The following is a description of a gene set: An abnormality of the regulation of body fluids. Human Gene Set: HP_ABNORMALITY_OF_FLUID_REGULATION Abnormality of fluid regulation studied in species Homo sapiens, and this is the list of marker genes: LCT, ATN1, SCNN1G, DOHH, MMACHC, TGFB1, SLC25A4, MVK, ITK, PTEN (NCBI Gene Id 8037), NUP85, SEC63, ACVR1, PSAT1, ACBD6, ACP5, FOXG1, BCL2, TXNRD2, ANKH, FECH, VSX1, ALG9, ADAMTS2, JAG1, COX16, GPC6, HNRNPK (heterogeneous nuclear ribonucleoprotein K), PEX5, PSMG2, DPAGT1, MYH7, KRT13, LAMA3, RBM20, INPPL1, TNFRSF1B, TLR4, COQ8B, SCN9A, PCCB, ALPK3, TNNC1, NIPAL4, MCM10, CLMP, LAMB3, ACTN4, MYPN, TGM1 (NCBI Gene Id 7051), USP8, ZNHIT3, BUD23, GATM, LAMB2, SLC34A2, HGD, FARSB, RRAS (NCBI Gene Id 6237), CASP10, GPR101, ERAP1, FBXO11, DSP, UROS, PSEN2, MEN1, SLC4A11, IL2RB, HELLPAR, ACADM, TAF6, MYH6, ATP6V0A4, TRIP11, CPN1, EFEMP1, IL6, GATB, MST1, RBM8A, NEXN, RRM2B, KIF20A, AQP2, GET3, GNPTAB, SCN11A (NCBI Gene Id 337933), PERCC1, PIEZO1, CAV1 (NCBI Gene Id 857), TBK1, SDHA, LAMC2, KLHL40, THSD1, EPCAM, EHHADH, FRMD4A, WDR35, IVD, KLHL41, F8, PLXND1, CCBE1, CYBB, MYL11, GTF2I, TCF4, NUP37, TMEM260, NEU1, NUP160, KCNN4, DEF6, COL8A2, WT1, IL23R (interleukin 23 receptor), FCGR2A, IL12A-AS1, DCHS1, CYC1, RIN2, SNORD116-1, ACAD9, MAPRE2, BMPR1A, ANTXR2, DNMT1, VPS51, EPB41, MYD88, CTNNB1, FASLG, ANGPT1, SLC12A1, RPL3L, IYD, CD79A, SLC5A1, GLB1, TSHR, SGPL1, IL10, ACSF3 (acyl-CoA synthetase family member 3), KIAA0586, ZNF408, MECOM, NDP (norrin cystine knot growth factor NDP), SPG11, HLA-B, GLA, BMP6, RPS10, SOS1, PRKCSH, GAPVD1, WNT7A, ADARB1, AVPR2 (NCBI Gene Id 554), ERBB3 (erb-b2 receptor tyrosine kinase 3), POMP, LAMA2, TAF1A, PTPN22, PSMB4, CCND1 (cyclin D1), TXNDC15, HPGD, CRB2, SPTB, LRP5, RYR1, ERG, GATA6, PCCA (NCBI Gene Id 5095), HESX1, HSD3B2, FIBP, CDKN1B, CBL, RAP1B, PTPN2, NAA10, MMUT, NUP205, CD247, PIK3CA, FHL2, KLF1, SLC1A3, CD244, SPINK1, AP1S3, IRAK1, PRKAR1A, RNF13, RAF1, CHD7, CALR, ALG1, EIF2AK3, LDB3, DYNC2I1, BLNK, RBMX, NDUFAF6, ADA, DHX30, PRKAG2, NPAP1 (nuclear pore associated protein 1), MPV17, AGXT, ARHGAP24, PLN, TICAM1, MT-CYB, TALDO1, SEMA4D, RRAGC, ASAH1, IGHM, TNNT2, TAFAZZIN, SLC29A3, SLC5A2, TMEM270, NSF, ADAMTS3, FZD4, KIF7, IFT140, NR3C1, FSHR, SLC4A1, B4GALT1, NRAS, PLVAP, TRPC6, MAP2K2, PKLR, NARS2, SLC25A13, ATP7B, SLC26A4, TBC1D8B, IL7R, FAS, F12, DOK7, HBA1, SPINK5, NKX2-6, NDUFS4, ASS1, EMP2, TNNI3, GCK, SLC5A5, SLC26A2, ALG12, CPT2, VCL, LRPPRC, SLC35C1, RPL26, SLC26A3, ENPP1, FLNB, CDKN2B, DDR2, SOX18 (NCBI Gene Id 54345), SCN5A (sodium voltage-gated channel alpha subunit 5), CAMTA1, PLD1 (phospholipase D1), SCNN1A, ALG8 (NCBI Gene Id 79053), FLNC, IRF4, PLG, NDN, CD46, TPM1, ACTB, ABCC8, CCDC88A, MKKS, LPIN2, ALB, LIG4, NEB, HLA-DRB1, CHRND, FLT1, DHCR7, CCN6, AIP, LHX3, SAT1, RPL11, NDUFB10, ATP1A3 (NCBI Gene Id 95633), MMAA (NCBI Gene Id 166785), IL36RN, BCKDHA, MRPL39, CDKN1A, CTNS, CAP2, ELN, EGFR, PPP3CA, VEZF1, DUOX2, CSRP3, B2M, FAT4, RAD21, SLC22A4, RB1, PLCG2, CLCNKA, FGG, TSPAN12, CFH, BUB1, MRPS16, PBX1 (PBX homeobox 1), COL5A1, RPL18, ASL (NCBI Gene Id 435), GNB2, MYBPC3, CELSR1, SPP1, NSD1, KIF11, POU1F1, TUBB, RASA1, ABCC6, CD55, SMC1A, STX1A, RPL5, GUSB, HS3ST6, PRRT2, BMP2, FGFR3, SUMF1, TMPO, CDH11, TRIP13, RPS20, NOD2, ERCC5, RPS7, HADHA, MDFIC, EBP, NUP133, KCNJ11, NAXD, CYP11A1 (cytochrome P450 family 11 subfamily A member 1), GNAQ, RAG2, CRLS1, BAP1, GBA1, TREX1, CD2AP, LIAS, GTF2IRD1, CD28, DOLK, PPCS, KPTN (kaptin, actin binding protein), DAAM2, ABCA3, UROD, NLRP3, ASPRV1, AGGF1, TPRKB, SMS, COG8, KLRC4, PDGFRB, BMPER, VPS33B, CA12, TTN, PDX1, NCF1, CFI, INS (NCBI Gene Id 3630), NUP107, MYO5B, CEP57, ACTC1, LYST (lysosomal trafficking regulator), PIK3R1, LTBP2, SPTA1, BLTP1, GRHL2, RMRP, HBA2, AHCY, EIF4H, CDAN1, KRAS, SPRED2, GATA4, IGSF3, IKBKG, PAX8, HLA-DPB1, ACTN2, SLC22A5, HEATR3, IL2RA, RAG1 (recombination activating 1), LIMK1, EPHB4, TLR3, CTRC, PMM2, LIPN, RPS17, LYN, HYMAI, ACTA1, HERC2, CSGALNACT1, PSEN1, TP53, TCAP, TSR2, RPL8, TEK, TMPRSS15, APOL1, CACNA1A, SFTPB, FLT4 (fms related receptor tyrosine kinase 4), COL1A1, NIPBL, PWRN1, MAGI2, DMD, BRAF, ACAT1, QRSL1, APOE, CORIN, SMC3, KCNQ2, CHRNG, COL5A2, MGAT2, GATA1, ZNFX1, LMOD3, MED12L, GRIP1, SCN10A, PEX2, CDC42, IFT80, RPL15, NEUROG3, HDAC8, CYP4F22 (cytochrome P450 family 4 subfamily F member 22), SGCD, RFC2, SDR9C7, APC2, MYLK, LARS2, COL11A1, TAPT1, HMGCL, STX11, NKX2-1, SNORD115-1, UNC93B1, SCN1A, BUB1B, PWAR1, PIK3CD (phosphatidylinositol-4,5-bisphosphate 3-kinase catalytic subunit delta), ALG14, TCF3, CRYAB, NUP93, AK2, PTPRO, DHPS (NCBI Gene Id 1725), MRPS22, FOXF1, SYK, ESAM, CPAMD8, FOXC2, TG, TWNK (NCBI Gene Id 60508), KNSTRN, PDSS2, KCTD1, PRSS1, DUOXA2, MAP2K1 (mitogen-activated protein kinase kinase 1), BRD4, DBH, C4A, HAND2, RPL9, BAZ1B, LZTR1, RPS24, HRAS, CYP1B1, DNAJC30, SERPING1, MUSK, TBL2, CYP11B2, RNU7-1, HAVCR2, FKBP6, JPH2, VPS37D, LHX4, SPTBN1, PRF1, CPSF3, AGBL1, MOGS, RANBP2 (RAN binding protein 2), UNC45A, CFTR, MAPK1, MPI, SNX14, SOS2, FGB, CDH23, SEC61A1, MIF, ANAPC1, PROP1, MRAS, GATC, CARS2, CITED2, GLE1, SCNN1B, ODC1, PRDM16, LBR, SMAD4, SPI1, CLPB, ADA2, TSC1, FIG4, TNFRSF11B, ANKFY1, IL2RG, SULT2B1, OVOL2, IL1RN, XPNPEP2, CDK5, ALOX12B, BTNL2, TRAF7, ENG, ERCC6, USP18, GYPC, XYLT2, POLG2, PKHD1, TBX20, FGA, DYNC2H1, RPL31 (ribosomal protein L31), UBR1, MKRN3, NFKBIA, ANKRD1, CHEK2, RPS15A, CCR1, KCNJ1, TRAF3, SLC39A7, RELN, HFE, RASA2, MYOC, COL2A1, FN1, VAC14, BUB3, PTH1R, MYO1E, WWOX (WW domain containing oxidoreductase), TSHB, PLAA, F5, KNG1, OCRL, IGLL1, MRPS28, GJC2, PTPN11, GTF2IRD2, LRRC8A, SLC35D1, SLC34A1, KRT2, ANGPT2, MMAB, CDKN2C, NOS3, CALCRL, OCA2, PHGDH, TTR (transthyretin), LMOD2, CIITA, BAG5, SFTPC, KIT (KIT proto-oncogene, receptor tyrosine kinase), RHD, SCN4A (NCBI Gene Id 6329), PTPN14, FKTN, COG6, TLL1, POLG, GATAD1, TSC2, MYOF, MEFV, RPL27, LMNA, RPS28, PIGN, OSGEP, TRIM37, FOXE1, GPR35, NAXE, KAT6A, BAG3, STAT4, BSND, ABCC9, IFIH1, RAB34, CPS1, C1QBP (complement C1q binding protein), LTBP4, ABCA12, TGFBI, SHANK3, SLCO2A1, HLA-DPA1, BCL6, RPS29, NPHS1, DIS3L2 (NCBI Gene Id 282696), CTSA, USP48, FOCAD, DNASE1L3, ANTXR1, LAMA4, STAG1, INF2, IFT56, ZFP57, MAGEL2, NR3C2, RRAS2, OTC, NEK9, DYSF, GSN, RPS26, ANKRD55, COL4A3 (collagen type IV alpha 3 chain), NPHS2, RIT1, TNFRSF1A, ARHGDIA, PRTN3, VEGFC, MTO1, COL1A2, IFNGR1, CHRNA1, EIF2AK4, ATP1A2, TBX1, TPO, METTL27, PLAGL1, NR0B1, CLIP2, RECQL4, ACAD8, RPS19, NKX2-5, SNRPN, PLCE1 (NCBI Gene Id 51196), NR1H4, NEK1, UBAC2, RPL35A, IL12A, MCEE, AGR2, PIGA, HSPG2, SCARB2, BPTF, DCLRE1C, GATA2, KRT10, JAK2, PRSS2, NFKBIL1 (NCBI Gene Id 4795), NR2E3, GAA, TRAPPC2, NAGA, SLC17A5, DES, CYP24A1, ATRX, ANLN, ZEB1 (zinc finger E-box binding homeobox 1), GBE1, RPL35, USB1, ARSL, NOS1AP, STOX1, STAT3, CTLA4, PAX2, DBR1, STX3, DYNC2I2, ACTG1, CD79B, PSPH (NCBI Gene Id 5723), CYBC1, CLCNKB, TIE1, LACC1, ALOXE3, DSG2, AKT1, POU4F1, OTULIN (NCBI Gene Id 90268), RPS27